The following is a description of a gene set: Human Gene Set: GOBP_POSITIVE_REGULATION_OF_SKELETAL_MUSCLE_TISSUE_REGENERATION Any process that activates or increase the rate of skeletal muscle regeneration. studied in species Homo sapiens, and this is the list of marker genes: HOPX, PPARD, SOX15, MYOD1, CAPN3